The following is a description of a gene set: Any process that modulates the frequency, rate, or extent of germinal center formation. species: Homo sapiens Human Gene Set: GOBP_REGULATION_OF_GERMINAL_CENTER_FORMATION, and this is the list of marker genes: PKN1, FOXJ1, BCL6, TNFSF13B, ADA, MEF2C, RC3H1, TNFAIP3